The following is a description of a gene set: studied in species Homo sapiens Human Gene Set: REACTOME_DAP12_SIGNALING DAP12 signaling, and this is the list of marker genes: SHC1, GRB2, TREM2, SYK, PIK3CA (phosphatidylinositol-4,5-bisphosphate 3-kinase catalytic subunit alpha), LCP2, BTK, TYROBP, PIK3CB, VAV3, PLCG2, LCK, KLRK1, LAT, KRAS, PIK3R2, GRAP2, PIK3R1, HRAS, SOS1, FYN, KLRC2, KLRD1 (killer cell lectin like receptor D1), RAC1, PLCG1, B2M, HLA-E, NRAS, VAV2